The following is a description of a gene set: studied in species Mus musculus Mouse Gene Set: REACTOME_ENDOSOMAL_VACUOLAR_PATHWAY Endosomal/Vacuolar pathway, and this is the list of marker genes: H2-Q1, H2-M2, H2-Q4, H2-M5 (histocompatibility 2, M region locus 5), H2-Q10, H2-M10.4, H2-M11, H2-T10, H2-M9, H2-M10.2, H2-M10.6, H2-K1, H2-M1 (NCBI Gene Id 333725), H2-Q7, H2-M10.5, H2-M3, H2-T22, H2-Q6, H2-T23, H2-M10.3, Lnpep, B2m, H2-Q2, H2-M10.1